The following is a description of a gene set: Human Gene Set: REACTOME_RUNX1_REGULATES_TRANSCRIPTION_OF_GENES_INVOLVED_IN_DIFFERENTIATION_OF_HSCS RUNX1 regulates transcription of genes involved in differentiation of HSCs studied in species Homo sapiens, and this is the list of marker genes: H2BC5, H4C14, H4C4, PSMA6, H3C7, PSMB3, H4C3, RPS27A, H2BC6, PSMA4, H4C9, ABL1, H3C4, H2BC3, PSMD13, PSMB5 (NCBI Gene Id 5693), SEM1, LMO1, PSMD14, H2AC6, H2BC26, H4C11, H2BC12L, H3C11, H2AC4, H3C1, H3-3B, H2BC8, H3-3A, GATA2, GATA3, H2BC14 (H2B clustered histone 14), H4C5, CDK7, H2BC12, H4C8, H3C3, CBFB, PSMD2, PSMC6, PSMB4, PSMD7, H2BC4, H2AB1, H4C13, UBA52, PSMD1, H3C8 (H3 clustered histone 8), TP73, H2AC18, TCF12, LDB1, H4C16, H2AC8, H2BC21, ADRM1, H2AX, H2BC7, H4C6, H4C1, MYB, PSMD12, UBB, PSMA3, H2AC14, PSMA1, H4C2, PSMC5, RUNX1, H2BC13, PSMC3, PSMC4 (proteasome 26S subunit, ATPase 4), PSMA2, PSMA7, PSMD6, H3C10, PSMC2, PSMB2, H2BC9, PSMB6, CCNH, H3C13 (H3 clustered histone 13), H2BC1, PSMB7, YAP1, H3C15, TAL1, H2BC17, MNAT1, LMO2, H2AC20, H3C12, GATA1, H3C6, TCF3, H2AC7, H2AJ, H2AC19, H4C12, PSMD3, UBC, SPI1, PSMD11, PSMB1, H3C2, H4C15, H2AZ2, PSMA5, PSMD8, KMT2A, H3C14, PSMC1, ITCH, H2BC15, H2BC11, H2BC10